The following is a description of a gene set: Expression profiling of Rag2-deficient Ets1++ and Rag2-deficient Ets1-- mature NK cells and WT bone marrow progenitors, WT T cells, and WT Pro B cells Human Gene Set: GSE37301_COMMON_LYMPHOID_PROGENITOR_VS_PRO_BCELL_UP species: Homo sapiens from publication Ramirez K, Chandler KJ, Spaulding C, Zandi S, Sigvardsson M, Graves BJ, Kee BL (PMID 22608498) Genes up-regulated in common lymphoid progenitor versus pro-B cells., and this is the list of marker genes: TMEM30A, NRIP2, RAB33B, CST6, FOCAD, MTNR1B (NCBI Gene Id 4544), GPX7, SCARF1, ZNF721, SNRK, GPR173, AJAP1, ALG8, GSPT2, BMP15, TXNRD3, CTR9, TXN, SUMO1 (NCBI Gene Id 7341), ZNF12, DHX32, IL1R2 (interleukin 1 receptor type 2), TNFSF18, URM1, SOX4, HYAL4, SAP30, TNNI3K, GOLT1B, SIGLEC1, NDUFAB1 (NCBI Gene Id 4706), PRELID3B, LRP5L, DGKQ, MYEF2, SLC35F6, CEP83, CASK, IBSP, AASDHPPT, LYPLA2, SLC17A6, AMPD1, PLSCR4, NTS, KLK5, OSBPL7, TOPORS, GNPAT, OPN3, ARHGEF15, DENND4A, UBE2B, KRT7, DLGAP4, ATP6AP2 (ATPase H+ transporting accessory protein 2), ZNF280A, SPN, TNFRSF11B, INE1, CA6, EIF3M, RAB3D, MS4A3, IER3 (immediate early response 3), TLR2, RRAS2, CALML5, COL11A1, YOD1, NEAT1, CPNE3, TSPAN2, CASP8AP2, KCMF1, UPK1A, PCGF2, PHYH, IFIH1, C1D, NTRK1, SLC2A10, MTHFD2L, CREM, NEK4 (NCBI Gene Id 8380), RDH11, RNASEL, SLC52A1, S100P, SUCLG2, CORO2B, OSGIN2, SERPINE1, OPRK1, ZNF32, DDX3X, CCDC51, QSER1, CCDC47, ZFPM2, GPR182, ERICH1, CYP39A1, GUCA2B, ELF3, PSEN2, BANK1, DCHS1, ID4, PYGM, ANGPTL2, CCDC28A, SEMG2, IFT57, TG, WDR82, SLAMF8 (SLAM family member 8), CDH7, HOXC6, REPS1, WWC2, ID2, IRGC, SOCS6, BAHCC1, PLEKHF1, KCNK13, TBL2, SNX13, GAR1, SLC16A2 (solute carrier family 16 member 2), MYL1, UQCC1 (ubiquinol-cytochrome c reductase complex assembly factor 1), RBBP7, RNF41, WSB2, ESRRG (NCBI Gene Id 2104), MTMR11, CSF1R, NDNF, GCFC2, ACO2, EFEMP2, RS1, SLC7A9, PIP5K1A, P3H2, ZNF8, SEC14L1P1, DGCR5 (NCBI Gene Id 85356), TCN2, SIX6 (SIX homeobox 6), HMGB2, POU5F1P4, KLF9, HTR3B, HCG9, OR2B6, COL6A2, PITPNM3, DOCK1, CADM4, AQP2, GPX5, ANXA1, WNT1, PYGL, C17orf75, LIPG, FBN2, JMJD1C, MIR22HG, EXOC6B, TRAPPC11, YBX2, HS6ST1, SV2C, MRPL20, PDE10A, SCN2A, CACNA1H, NLE1, NKX2-8, DOC2A, GRM2, ACSM1, PADI1, ECEL1, CENPC, PAX1, CELA2B, PCNP, SLC14A1, OR2F2, HRG, ZNF34